Given this list of marker genes Atp10a, Atp10b, Abca3, Atp8b2, Atp8a1, Atp8b1, Abca4, Atp11c, Atp8b5, Abcb1b, Abcb1a, Mfsd2a, Atp8a2, Atp11a, here is a description of the gene set: Mouse Gene Set: GOMF_GLYCEROPHOSPHOLIPID_FLIPPASE_ACTIVITY species: Mus musculus Catalysis of the movement of a glycerophospholipid from the exoplasmic to the cytosolic leaflet of a membrane, using energy from the hydrolysis of ATP.